Given this list of marker genes CYP11B2, here is a description of the gene set: part of: Metabolic disorders of biological oxidation enzymes Cytochrome P450 11B2, mitochondrial (CYP11B2 aka aldosterone hydroxylase) is an enzyme necessary for aldosterone biosynthesis via corticosterone (CORST) and 18-hydroxycorticosterone (18HCORST). Defects in CYP11B2 results in disorders of aldosterone synthesis. Corticosterone methyloxidase 1 and 2 deficiencies (CMO-1; MIM:203400 and CMO-2 deficiency; MIM:61060) are autosomal recessive disorders of aldosterone biosynthesis. In CMO-1 deficiency, aldosterone is undetectable in plasma, while its immediate precursor, 18HCORST, is low or normal. In CMO-2 deficiency, aldosterone can be low or normal, but at the expense of increased secretion of 18HCORST. Patients with CMO-2 deficiency have elevated plasma 18-hydroxycorticosterone/aldosterone ratios. studied in species Homo sapiens Reactome Pathway: Defective CYP11B2 causes CMO-1 deficiency